The following is a description of a gene set: Human Gene Set: GOBP_NEGATIVE_REGULATION_OF_IMMUNE_EFFECTOR_PROCESS Any process that stops, prevents, or reduces the frequency, rate, or extent of an immune effector process. species: Homo sapiens, and this is the list of marker genes: TGFB1, CD80, APOA1, TGFB2, MAPK3, TBX21, SUSD4, CCR2, ZPBP2, TNFSF18, LGALS9, ATG9A, C4BPB, IFNB1, HLA-E, ARG1 (arginase 1), NCKAP1L, TIGIT, DUSP22, PGLYRP3, CD96, IFNL1 (NCBI Gene Id 282618), PTPN6 (NCBI Gene Id 5777), LGALS1, APPL1, ACP5, SOCS5, FOXJ1, RC3H1, CLEC4G, CEACAM1, LILRB1, CD274, LGALS3, MICA, SPINK5, PARP3, RABGEF1, TNF, EPX, SMAD7, FOXP3, HLA-G, HLA-F, RPS19, SPN, INPP5D, IL2, C4BPA, STAT5A, APOA2, BCL6, IL20RB, CD300A, NECTIN2, PGLYRP1 (NCBI Gene Id 8993), HFE, IL4R, VSIG4, CD46, CD69, LILRB4, CX3CR1, PDCD1, ANGPT1, IL33, ARRB2, BCR, PPP3CB (NCBI Gene Id 5532), AXL, HLA-B, CRK, RC3H2, TNFSF4, NECTIN4, CR1L, PVR, BST2, SLAMF1, ENPP3, KIR2DL4, INS, FOXF1, NDFIP1, LOXL3 (lysyl oxidase like 3), IFNA2 (interferon alpha 2), CLEC12B (C-type lectin domain family 12 member B), ANXA1, CD55, CUEDC2, SERPINB4, CR2, IRAK3, A2M, GRB2, PRG2, ZBTB7B, SERPING1, IL7R, GRN, ZC3H12A, CD84, AHR, XCL1 (NCBI Gene Id 92337), UFL1, SLAMF8, USP5, FER, IL10, TWIST1, PTPRC, MIR302A, SERPINB9, IL4I1, HLX, TGFB3, CD59, KLRC1, HAVCR2, ASCL2, MASP1, FCGR2B, KLRD1, NLRX1, IL13RA2 (interleukin 13 receptor subunit alpha 2), PGLYRP2, FCRL3, SPI1, FGL2, JAK3 (Janus kinase 3), TMBIM6, DUSP10, HLA-A, CD22, CR1